The following is a description of a gene set: Human Gene Set: MIR8086 Genes predicted to be targets of miRBase v22 microRNA hsa-miR-8086 in miRDB v6.0 with MirTarget v4 prediction scores > 80 (high confidence targets). species: Homo sapiens from publication Chen Y, Wang X (PMID 31504780), and this is the list of marker genes: DAAM1, NECTIN3, CCT4 (chaperonin containing TCP1 subunit 4), HNRNPA0, FYN, TMEM196, GALNTL6, NLGN1, UTP14C, FBXO30, VAPA, TRAF3, ADAMTS8, CNKSR2, ZMYND11, GPBP1, BDH2, CYSTM1, RAB22A, KBTBD2, TDRD15, ZNF74, SPCS3